The following is a description of a gene set: Neighborhood of AIP Human Gene Set: GCM_AIP studied in species Homo sapiens Neighborhood of AIP aryl hydrocarbon receptor interacting protein in the GCM expression compendium, and this is the list of marker genes: LMNB2, AQP2 (NCBI Gene Id 359), SLC29A2, HDAC1, SMARCC1, TIMM17A, ARHGAP4, PRKAG1, ABCC1, AIP, PLK1, DRAP1, POLR2K, ZNF76, PRMT1, DHPS, WAS, FANCC, DDX18, TRIP13, GPER1, UBE2D3, TTF1, BCAT2, NEFL, ILF2, RENBP, PDE6B, DRG2, SMARCD2, BLMH, MIEF1, HNRNPL, NONO, SCAF11, PMS2P11, ARHGEF1, VAV1, SIGMAR1, SF1